The following is a description of a gene set: species: Homo sapiens Impaired conduction of cardiac impulse occurring anywhere along the conduction pathway. Heart block Human Gene Set: HP_HEART_BLOCK, and this is the list of marker genes: DMPK (NCBI Gene Id 60405), DEF6, SLC4A3 (solute carrier family 4 member 3), CDH2, TTR, KCNE3, KCNJ18, SCN1B, FRG1, CAPNS1, GPC3, GLA, MYH6, KCNK3, MMP2, CPT2, SCN2B, RYR2, RAF1, SGO1, TMEM43, PRKAG2, BRAF, SCN4B, CALM3, PSEN2, CACNA1C, EMD, TBX5, HLA-DRB1, SCN3B, CNBP, PKP2, ATP6V1E1, NPPA, TRDN, PLEC, PHYH, TBX20, LDB3, CACNA2D1 (NCBI Gene Id 781), CASQ2, GYG1, FHL1, SMCHD1, DES, LARS2, PPP1CB, GPC4, CITED2, GPX4, RMRP, KCNJ5, AGXT, AKAP9, DYSF, VEZF1 (NCBI Gene Id 7716), MYBPC3, POLG2, LEMD2, GRIN1, GNB5, ACTC1, SCN5A, MT-CYB, EXOSC5, SEMA3A, KCND3, MMP14, MYL2, KCNQ1, LMNA, TRPM4, CACNB2, KCNE5, TNNT2, CACNA1S, PEX7, KCNJ2, MYL4, CALM1, KCNH2, SYNE2, ABCC9, LRP1, GJA5, SLC25A20, GNAI2, MT-ATP8, TNNC1, MYH7, SCN10A, GATA4, PIGU, PTPN11, JUP, GATA6, DUX4L1, DTNA, DNMT3B, FLNC, CALM2, MYOZ2, RRM2B, KCNJ8, MT-TL1, TNNI3K, MYPN, BANF1, DOHH, LMOD2, SYNE1, TTN, GNB2, PSEN1, CACNA1D, CTNNA3 (catenin alpha 3), LAMP2, NKX2-5, HCN4, SLMAP, SCNN1A, DSG2, BTNL2, DUX4, RANGRF, POMT2, BVES, TLL1, GABRA3, CDC45 (NCBI Gene Id 8319), RNASEH1, ACADVL, GPD1L, ACTN2, PRKG2